The following is a description of a gene set: Human Gene Set: GSE40274_FOXP3_VS_FOXP3_AND_HELIOS_TRANSDUCED_ACTIVATED_CD4_TCELL_UP Genes up-regulated in CD4 T conv over-expressing: FOXP3 versus IKZF2 and FOXP3. species: Homo sapiens from publication Fu W, Ergun A, Lu T, Hill JA, Haxhinasto S, Fassett MS, Gazit R, Adoro S, Glimcher L, Chan S, Kastner P, Rossi D, Collins JJ, Mathis D, Benoist C (PMID 22961053) The transcription factor FoxP3 partakes dominantly in the specification and function of FoxP3+ CD4+ T regulatory cells (Tregs), but is neither strictly necessary nor sufficient to determine the characteristic Treg transcriptional signature. Computational network inference and experimental testing assessed the contribution of several other transcription factors (TFs). Enforced expression of Helios or Xbp1 elicited specific signatures, but Eos, Irf4, Satb1, Lef1 and Gata1 elicited exactly the same outcome, synergizing with FoxP3 to activate most of the Treg signature, including key TFs, and enhancing FoxP3 occupancy at its genomic targets. Conversely, the Treg signature was robust to inactivation of any single cofactor. A redundant genetic switch thus locks-in the Treg phenotype, a model which accounts for several aspects of Treg physiology, differentiation and stability., and this is the list of marker genes: AGFG2, LHPP, PLXNB3, NPFFR1, TFPI, COLEC12, DYNAP, BMF, GUCA2A, ALX3, ANKRD29, ZBTB16, SEMA5A, TMEM41A, MTTP, PLPPR3, MED25, SSTR2, CLN5, CX3CR1, ERBB3, KNDC1, FANCE, PKD2L1, NEFL, ZFP30, GPATCH3, TMEM52, SYT5, DCC, LMNB2, SCNN1B, SLC4A11, NUP50, PCDH12, LTB4R, E2F1, MID1IP1, DHRS2, DNAJC28, MFSD6L, SULT1B1, DYTN, GRIP2, SPACA6, INTS5, STPG1, SGCZ, CHIA, INF2, CSNK1E, CCDC40, BLTP3A, HTR1D, ADAMTS1, TEKTL1, KLHDC9, CDKN2A, RHCG, KIF5C, FZD1, GCDH, SLC45A1, NFKBIL1, S1PR5, HRCT1, CAPN11, RNF151, ZFYVE19, PLOD3, CALHM2, C2CD4C, ANKRD6, PDIA5, MIR542, FGR (FGR proto-oncogene, Src family tyrosine kinase), LIPG, FZR1, ATOH8, AMER3, SPATA31D3, ABCD2, POU3F1, MYO7A, PIK3R2, C12orf56, SLC22A15, FLACC1 (NCBI Gene Id 65070), COL8A2, LHX5, GRHL1, NPBWR1, NHERF4, ANKRD1, SORBS1, ZNRF4, FAM83E, KLF8, HTRA3, ADAMDEC1, TMEM138, CASP7, SREK1IP1, CENPT, KLHL36, UNK, IL1R1, CLRN1, ACTA1, COQ9, LRRC56, MYOZ1, DMRTB1, TRMO, DNAAF4, SCHIP1, ZPBP, STX11, SPRY2, CYSRT1, GRB14, IGFBP6, RPS6KA2, TBX3, OTOP3, RBM10, GPR88, CCDC166, RETSAT, NEBL, CLIC3, PDE4DIP, LMF1, NTRK2, TTLL10, FRMD4B, TMEM171, INA, MOG, LHX3, PARAL1, WDR35, CD101, P2RY12, TENM4, APBB2, TNFRSF9, WDR5B (WD repeat domain 5B), ADORA3, RGS22, SNX15, MED26, IGDCC4, AKAP12